Given this list of marker genes UVRAG, ARHGAP21, RIPOR1, STK25, DAB1, NHERF1, YWHAZ, TBCCD1, COPG1, ARCN1, CDC42, HOOK3, PDCD10, STK11, here is a description of the gene set: Any process in which the Golgi is transported to, and/or maintained in, a specific location within the cell. Human Gene Set: GOBP_GOLGI_LOCALIZATION species: Homo sapiens